Given this list of marker genes MGST2, EMILIN1, ISYNA1, NDRG2, SASH1, COX7A1, GUCY1A1, MUSTN1, DSTN, MXRA8, ACTB, ACTA2, RNASE4, ADCY4, MFGE8, NRGN, PDLIM1, NR2F2, GSTM3, COL14A1, FLT1, TAGLN, BCAM, FRZB, CAVIN3, MYLK, KANK2, LGALS1, TCEAL4, IFITM3, TCEAL1, DBNDD2 (dysbindin domain containing 2), ADIRF, LTBP4, CHCHD10 (NCBI Gene Id 400916), CCDC102B, TJP1, SLC7A2, NFIB, ETS2, COL6A2, TNS1 (tensin 1), FBN1, LMNA, RASL12, TPM1, EPB41L4A-AS1, HLA-F, COL6A3, TGFBR2, LDB2, SELENOP, PRKG1, IGFBP5, ST13 (ST13 Hsp70 interacting protein), ACTN4, UTRN, GUCY1B1, MGP, TINAGL1, CRIM1, S100A11, SLC40A1, JAG1, TM4SF1, ITGB1, TBX2, ITGA1, IMPDH2, NDN, NBL1, MT2A, LBH, RHOB, CSRP1, FXYD1, IGFBP4, PLAC9, RRAD, PDGFRB, RGS5, ADAMTS5, CRIP1, ANGPT2 (angiopoietin 2), DDR2, CAV1, CD59, MEG3, GNG11, SELENOW, IGFBP7, MT1E, ARHGEF17, TIMP3, PLPP3, OAZ2 (NCBI Gene Id 4947), ADGRF5, BEX3, PALLD, SEPTIN4, NUPR1, COL12A1, CDKN1C, SERPING1, A2M, TCEAL9, GJA4, NDUFA4L2, MAP1B, CD9, PRSS23, PPP1R12A, ARHGAP29, GJC1, CCN2 (NCBI Gene Id 1490), PDE1A (phosphodiesterase 1A), CAVIN1, EMP2, CAV2, HLA-B, RARRES2, MYL9, ITGA7, CD151, COL1A1 (NCBI Gene Id 4970), HLA-C, IFI27, WNT6, PKIG, SNRK, FILIP1L, GUCY1A2, IFITM2, TBX2-AS1, CALD1, H2AJ, MEF2C, RRAS, CTHRC1, SMOC2, PALM2AKAP2, SOD3 (superoxide dismutase 3), ETS1, LGALS3BP, MYL6, PPP1R14A, CRIP2, GPX3, CALM2, MCAM, C11orf96, BGN (biglycan), TPM2, CTSF, ESAM, EPHX1, EPAS1, PTP4A3, SDC2, SPARCL1, CALM1, NOSTRIN, NOTCH3, SGCE, B2M, COL6A1, LIMS1, IGFBP2, HES4, MYH9, CCDC80, EGLN1, here is a description of the gene set: The reproductive and endocrine functions of the ovary involve spatially defined interactions among specialized cell populations. Despite the ovary's importance in fertility and endocrine health, functional attributes of ovarian cells are largely uncharacterized. Here, we profiled >genes in 257 regions from the ovaries of two premenopausal donors to examine the functional units in the ovary. We also generated single-cell RNA sequencing data for 21,198 cells from three additional donors and identified four major cell types and four immune cell subtypes. Custom selection of sampling areas revealed distinct gene activities for oocytes, theca, and granulosa cells. These data contributed panels of oocyte-, theca-, and granulosa-specific genes, thus expanding the knowledge of molecular programs driving follicle development. Serial samples around oocytes and across the cortex and medulla uncovered previously unappreciated variation of hormone and extracellular matrix remodeling activities. This combined spatial and single-cell atlas serves as a resource for future studies of rare cells and pathological states in the ovary. from publication Jones ASK, Hannum DF, Machlin JH, Tan A, Ma Q, Ulrich ND, Shen YC, Ciarelli M, Padmanabhan V, Marsh EE, Hammoud S, Li JZ, Shikanov A (PMID 38578993) Human Gene Set: JONES_OVARY_PERICYTE Marker genes selected by filtering the centroid data for genes with a value > 0 for the given cell type studied in species Homo sapiens